The following is a description of a gene set: Progressive external ophthalmoplegia Human Gene Set: HP_PROGRESSIVE_EXTERNAL_OPHTHALMOPLEGIA studied in species Homo sapiens Initial bilateral ptosis followed by limitation of eye movements in all directions and slowing of saccades., and this is the list of marker genes: MT-TL1 (mitochondrially encoded tRNA-Leu (UUA/G) 1), MT-ND5 (mitochondrially encoded NADH:ubiquinone oxidoreductase core subunit 5), RRM2B, RNASEH1, MT-TT, TK2, POLG, LRP12, MT-ATP8, OPA1, DNA2, MT-TK, MT-TN, MT-TS2, MT-TQ, POLRMT, ATXN3, MT-ND1, MT-CO2, POLG2, MT-TF, SLC25A4 (NCBI Gene Id 7872), TAMM41, TWNK, TYMP, VARS2, MT-TH, RILPL1 (Rab interacting lysosomal protein like 1), GIPC1, DGUOK, APTX, MT-TL2, TOP3A, MT-CO1, MT-TW, MT-CO3, C1QBP, NOTCH2NLC, MGME1, MT-ND6, MT-ND4